Given this list of marker genes PUS7L, DDX18, MIR6090, ITGA4, LINC01068, MRPL40, RNU6-1043P, MEAK7, EVI5, CCDC194, SSBP1, ATXN2L, WIPI2, RNA5S6, S100A2, ZKSCAN3, CWC25, WDR70, KLHL20, TSHZ2, VPS33B-DT, TGFBR3, TMEM242-DT, FAM86B3P, TIMM21, CCDC117, NAA80, MBD1, ZNF821, ARL5AP1, HSPE1-MOB4, ITPRIP, HNRNPR, CCDC90B, COPS7A, BOLA1, FXYD3, KCTD15, TMEM242, RAD50, EPCIP-AS1, RN7SKP276, SIN3B, ORMDL1, RN7SL19P, SPESP1 (NCBI Gene Id 83599), ENSG00000260288 (novel transcript), ZNF214 (zinc finger protein 214), COL4A6, RNU4-71P, MT-TN, SFSWAP, DXO, BMS1P4, CIP2A, PTPN4, TMEM199, ACOT13, EVI2B, SLC33A1, DTL, ZNF518A, TBKBP1, MT-TY, SERTAD3, APOBEC3C, TMEM259, MRTFA-AS1, MNAT1, NLRP14, DYNLL2, ATAD3A, DUSP6, ERVK3-1 (endogenous retrovirus group K3 member 1), BOLA3, ZFP1, WIZ, EIF3F, ENTPD6, RN7SL278P, CAMLG (calcium modulating ligand), WEE2-AS1, ZNF497-AS1, ARID1A, MT-TA, ATPAF1, TM7SF3, MAP2K5, ZNF791, LINC00620, ADIPOR2, COPS2, WNT2B, SRCAP, CNIH3, NUDCD1, RTEL1, MTMR4, PEX14, RABEP2, IRAK4, KAT6A (NCBI Gene Id 7994), FOCAD, FBXO15, DENND2B, PTK2, ABCD3, FBXL4, ARK2N, RAB11A, CIMAP3, ARF3, LINC01535, RSRP1, FAM20C, CCDC88A, ZNF790-AS1, NRSN2, DHX38, NOL12, SPRED1, LINC00963, PACSIN1, ODAD4, BTK, LGALS13, MITF, YJU2B, DUS1L, TRMT5, CLCN6, EBLN3P, MCMBP, MRPS18A, GLUD1P3, LRRC49, ANKRD54, LINC01411 (NCBI Gene Id 101928176), NRSN2-AS1, TIMM17B, ADSL, EIF2B3, NDUFAF4P1, ZNF131, RPS14, PQBP1, TOM1, MAN2C1 (mannosidase alpha class 2C member 1), PLEKHA6, ESYT1, KRI1, APC2, LINC00649, CCDC180, ATP2C2-AS1, NDUFAF5, CDC42SE1, EIF2D, RPL31P61, KCTD5, MMP16, COMMD4, ZFP91, CKAP2, MAP1LC3B, RTL8B, HEMGN, DCAF15, RGL2, KBTBD4, MAGOH-DT, GALK2, SNHG20, PDCL2P2, BZW1, USP3 (ubiquitin specific peptidase 3), ETFA, SAAL1, RMRP, EIF3D, MAD2L1BP, CFAP74, PPP2R2A, BMS1P4-AGAP5, CRBN, MED23, PAAF1, ENPP3, FAM227B, TOR1AIP1, MIR548AA2, RTEL1-TNFRSF6B, CDC45, SLC35A1, EML2, NSUN3, SKA3, RPL34, SIRT7, VPS33B, NF1, IGFLR1, MRPL44, TMEM167B, C1orf35, RCC2P4, EDC4, LONP2, MIR4457, ENSG00000231252, GPRC5C, GPA33, ELAC1, ZNF721, GABPB2, TAF9, DLEU2, RUFY1, SUGT1-DT, HSPE1, DPH1, MYBBP1A, CCR7, ENTPD1-AS1, GINS3, ARID4B, MIS12, ENSG00000237813, ALG10, GPI, RNU5B-4P, MCM3AP, ADAR, NDUFV2, RN7SL521P, CDC42EP3, BCS1L, ZNF491, MTA3, ZNF546, GNAL, ZNF575, ESF1, FRMD4B, METTL5, CREBL2, REEP4, NUP58, DZIP3, MSRB2, FAM136A, NUDT19-DT, TUBGCP3 (NCBI Gene Id 10426), CYP1B1-AS1, DHPS, OR2A1-AS1, KIF20B, ST13P16, TBK1, CDADC1, PUS10, MKNK1, CCDC90B-AS1, LPCAT2, PREX2, RNU6-1176P, TAOK3, ZNF391, APOO, STAT6, EFCAB7, FAH, LAMTOR5, SMG8, ZBTB7B, RPL34-DT, HSPBP1, NR2F2-AS1, THAP12, KIAA0513, YBX3, GPR161, CSTF2T, HIRA, IL10RA, RC3H2, SERPINB6, STARD3NL (STARD3 N-terminal like), STX16-NPEPL1, APOBEC3D, ABCB8 (NCBI Gene Id 11194), ARPC1A, LRP3, NME1-NME2, AK6, USP30, EP400P1, MRPS33, NOC3L, SREK1IP1, POLR3B, CNN3, MIR7-3HG, PAFAH2, HNRNPA1P37, LINC02341, MDC1, LINC02953, ARHGEF7, RNU6-470P, PSAP, ZNF585B (NCBI Gene Id 92285), DDX55, HELQ, HYAL3, RABGAP1L, ACBD5, DNASE1L1, ZNF234, SEH1L, ETS1, RNF224, AAGAB, SNORD60, CARMN, TOMM20, SMIM14, NEAT1, VSTM4, SH2D5, CAND1, RFTN1, HSPD1P21 (heat shock protein family D (Hsp60) member 1 pseudogene 21), DERL2, TCERG1, C18orf21P1, ZNF568, DNAJC25, DHRS13, CNIH3-AS1, CLK3, FAS, USP21, VARS1, BRWD3, KRTAP5-14P, IQCH, ZNF540, PRCC, RN7SL100P, SLC2A1, ZNF300, ACSL1, MTIF2, RNVU1-15, S100PBP, BMPR1A, RPL36A, C19orf12, GALE, CBX1, ZNF112, TAFA2, C2CD6, RAI14, ITGB3BP, FGF13, ZNF330, CALCRL, MARK4, MAP3K12, TTI2, CCNB3, MRTFA, AMOT, CCNO-DT, WWP2, DYRK4, ZNHIT3 (NCBI Gene Id 9326), RNA5SP473, RNU6-1107P, ADAT2, KRBA1, NSMCE1, NCAM1, DNAJC25-GNG10, GFUS, ZYG11A, PTPN2, LINC00868, NACA, RPL12, NSMCE1-DT, METTL3, ASPSCR1, G6PC3, FRA10AC1, KLHDC1, POLR3G, APBA3, CHST11, GAPDHP31, TBC1D19, SCD, ADNP, SDHDP2, SKIC3, TVP23B, COL4A2, TRAM2, ZSCAN16-AS1, NPAT, UQCC6, CTNS (cystinosin, lysosomal cystine transporter), PWWP2A, EYA4, ANO8, CITED2, ARSK (NCBI Gene Id 153642), RIGI, ZNF585A, KLHDC10, TCF4, NUF2, ZNF425, ZNF146, CDK5RAP1, SERTAD3-AS1, ISLR2, ELOCP32 (NCBI Gene Id 106481964), DYNC2I2, CARD8-AS1, DAXX, EEF1D, MEGF10, COX7A2, ZNF490, HMGB1, LAS1L, SEC14L1, BSDC1, SS18, RPL21, BOLA3-DT, CORO1A, SNHG19, LRP1B, PHYH, HTR5A, SYP, PPM1K, DPM3, TLCD5, ENSG00000252923, ZNF582, CCDC85B, COMMD10, PSMD9, MTFR1P1, RPL37, MBLAC2, PAK4, GTF3C5 (NCBI Gene Id 95853), SLC35E2B, ZNF609, UGDH, PRPF3, KNTC1, FMR1, CACNG5, ZSCAN9, SERTAD2, SNX1, B4GALT7, PIEZO1, MATCAP2, UBB, ITCH, TMEM18, USPL1 (ubiquitin specific peptidase like 1), MAGOH, TMEM147, RPA2, LINC02941, RRAS, ARHGAP29-AS1, ACTN4, DEUP1, MAZ, CDHR3 (cadherin related family member 3), PGM1, CDKN2C, IL5, CSRP1, GALT, DRAIC, PRSS27, COX4I1, RPL21P28 (NCBI Gene Id 100131205), LINC02890, MIR1302-3, ATM, SNHG7, ZC3H10, MIR4727 (NCBI Gene Id 100616416), AGAP5, TMEM68, LINC01719, ANK3, NFIA, ARID5B, PRPF18, IDS, SCAMP1, CCDC159, STING1 (NCBI Gene Id 340061, stimulator of interferon response cGAMP interactor 1), TPD52L1, NXPH3, ENSG00000267058 (novel transcript), ZNF223, SPOCD1, GRPEL1, ECHDC1, ZNF410 (zinc finger protein 410), BMP5, EGLN2, COX11P1, SCAND1, ZNF644, WDR36, PEX13, C1orf162, GOLGA1, KLHL11, CTNND1, ERLIN2, ENSG00000233230, VPS51, C12orf76, NAE1, THTPA, SUPT5H, BRD3OS, RNU6-2, ATG5, RGN, KRAS, CCDC103, LINC01547, CYP4X1, TMC7, CACNB3, PLD1, NUDT19, RHOC, DUSP22, ROR2, CLUL1, KRT18P68, STX16, NME9, USP15, CLIP1, HDGF, MCM3, KDSR, ACTR3B, KPNB1, POLDIP2, PPP6C, ZBED6, H3-3B, EIF5, RPS4XP20, RINT1, NARS2, C11orf68, GLS2, MRPL30, TUBG2, TPST2, USP31, SMARCD2, SEC23IP, GNB2, GCLC (glutamate-cysteine ligase catalytic subunit), CNBD2, HGS, DYNLL2-DT, NMRAL1, CCBE1, RPL38, GSTCD, MORF4L1, SNAP91, GOT2, DMAP1 (DNA methyltransferase 1 associated protein 1), ATE1OSP, ZNF280D, LINC01981, RPS3A, HIVEP3, SMIM26, RBPMS, RARS2, RMND1 (required for meiotic nuclear division 1 homolog), SDAD1, RFXAP, LINC02846, PRMT5, NRBF2, DHFR2, SNAP47, TFEB, TEX38, ZNF212 (NCBI Gene Id 7988), LINC02293, HMGA2, NPAS3, ZSCAN25, CFAP276, AARSD1, GTF2H4 (NCBI Gene Id 2968, general transcription factor IIH subunit 4), RNA5SP516, TAF15, INTS4, RESF1, COL4A1, METAP2, ACTA2, MYOM2, TAMM41, PLCE1, AASDHPPT, HCG9, DYNLL1, JPX, ZNF524, LSM8, RPP40, RNU6-535P (NCBI Gene Id 106479803), RNU7-179P, UFD1, CCNO, BEND2, ZNF566, CLIC4, MT-TC, TMBIM6, CAV2, SLC35A3, ZKSCAN4, ZNF829 (NCBI Gene Id 374899), FAF1, SMARCA1, DTD1, MIR7-3, E2F7, ST3GAL1, CNNM2, TXNL4B, METTL16, RHOBTB3, GPR37, IQCK, IREB2, RPL36A-HNRNPH2, OLIG1, URGCP, NKAP, GGACT, TDP2 (tyrosyl-DNA phosphodiesterase 2), BRK1, ABR, MIR5188, HIKESHI, RSRC2, ANKRD46, CSDE1, MRPL58, TMEM9, SMG5, CWC27 (CWC27 spliceosome associated cyclophilin), HEBP2, RAI1, POLDIP3, TBX18, GAPVD1, DAB1, RNU5A-8P, WTAP, AURKAIP1, RBMX2, ABCD4, RGS5, CEP170, KIF2A, RPL19, MRPS14, SLC24A1, PPP4R1, INTS12, H1-2, INTS14, RNU5A-5P, GFM2, NR1H3, CKAP4, CXXC1, ACP2, C17orf75, ACOXL, SMPD4P1, PSMA6, CHD3, SH3BGRL2, UTS2B (NCBI Gene Id 257313), THAP10, IGHMBP2, SYT4, ZNF264, ZNF461, DIO3OS, GEMIN7, ZNF396, ZNF565, RNU6-947P, COL4A5, TASOR2, RNF6, PMS1, ZNF404, STAT1, RNU11, DISC1, EPS15, ATP6V0A2 (NCBI Gene Id 7854), ATRX, ENSG00000212187, UROS, ELOVL1, TRIP10 (thyroid hormone receptor interactor 10), LARS2, NRAV (negative regulator of antiviral response), RN7SL322P, RPL27, PLEKHM3, CCDC107, BCL2L2, FAM187A, VARS2, CAV1, VRTN, PPM1K-DT, TCF12, MT-TF, NUDT17, PCBP1-AS1, TYW1, MLEC, NSUN4, OPTN, STK19, TUBD1, ATP6AP1L, MEMO1, MRPS18C, MT-RNR1, PAX9, PML, TMEM54, MITD1, CBX5, CNIH3-AS2, TSFM, CDCA4P2, ENC1, BCL2L2-PABPN1, TRPV2, MSL2, SCN8A, SUGT1, TATDN2, UEVLD, DTWD1, VDAC3, OCEL1, GTPBP3, TMTC2, VDAC2P2, WDR11-DT, ERVFRD-1, SMIM8, SERTAD1, C2CD5, CEP164, IL2RB, ZNF582-DT, DCP1A, BLOC1S1, HSPD1, EXOSC3, LAMTOR5-AS1, EP300, MED18, ENSG00000267448, HACD3, PAQR4, KCNK1, UBC, STMN3, MAPK14, SMG7, CTSC, MIR4530, ZFP30, POLR2KP2, EMC8, SLC38A6, NDUFS7, BRD7, ZKSCAN8P1, ZNF571 (NCBI Gene Id 55594), KPNB1-DT, ADRA1A, BLOC1S6 (biogenesis of lysosomal organelles complex 1 subunit 6), MYO19, ITPR1, NAPG, SNRNP27, TPR, FMC1, FIZ1, MIGA2, FMC1-LUC7L2, LINC01703, MRPL54, LINC01775, ENSG00000232995, TPGS1 (NCBI Gene Id 91978), MTHFR, FUT10, GBA1, RPL7L1, RYK, HIGD1AP5, GON4L, COA4, ZNF175, AKR1A1, MRPS31P4, CCDC9, ASF1A, STRADA, LINC02896, PSPC1, FKBP7, DCLRE1A, CCDC14, CEP72, TIMM44, ALDH7A1, MUC20-OT1, ICAM4, ARMT1, ZNF221, ELAPOR1, ZNF106 (NCBI Gene Id 64397), CEP126, ABCF2, UBE3D, ZBTB11, LRRC71, SMG7-AS1, YBEY, CMAHP, RN7SL819P, RXYLT1, SSR3, GPR108, VPS25, YARS1, TMEM170A, SCAPER, MIR4676, IGFBP6, CFAP298, SLX9, RGS14, TMEM19, LDAF1, PARK7, UTP3, NR3C1, OGT, ZNF251, ZNF302, MDP1, MIR4662B, KDM1A, YWHAQ, ZNF550, CBX1P2, SSBP2, TRABD (TraB domain containing), MTR, ZNF398, N4BP3 (NCBI Gene Id 23138), CNTLN, SLCO5A1, DNAJB4, NME1, DRAP1, ZSCAN22, EXOSC8P1, SNAP23, CIZ1, TRAF7, VPS26A, POMT2, RNU6-142P, ADGRL2, ENSG00000247416, ARMC5, COL21A1, PPP1R15A, LRRC14B, LRSAM1, ZNF607, BCCIP, AP4B1, SPOP, POLD2 (NCBI Gene Id 5425), MIR4662A, CA5BP1, GGPS1 (NCBI Gene Id 9453), AARS2, NHLRC2, MTF2, LINC02136, EIF1, MISFA, SCN1A, NEMP2, MTCO3P12, ZNF227, MVB12A, CCDC178, RPL32P28, CFAP298-TCP10L, ZNF385A, GATAD1, TMEM79, TRAM2-AS1, BAZ2A, STRA6, BAZ2B (NCBI Gene Id 29994), PPT1, DPP9, HLA-F, CDK13, PAIP2, APEX2, NSA2, MIR4734 (microRNA 4734), EPS8, TMEM101, DPY19L4 (dpy-19 like 4), RNA5SP117, IPO4, CDK12, FILIP1, KAZALD1, SZRD1, SNRPE, PRMT5-DT, RAD17, PIGG, NOPCHAP1, RAF1, TLE6, MRPL21, RN7SL262P, PEX3, CRYM, TBCB, ZNF81, DIAPH1, ATG16L2, EXOC1, PEX11G, TTN-AS1, FAM151B-DT, ZNF25-DT, ZNF25, SIGMAR1, MBTPS1-DT, IGF2BP2, ANXA2R, NFIC (nuclear factor I C), TACO1, CDC42EP4, IQSEC2, EFTUD2, TJP1, TGS1, ATG101, SRSF3, POLR2I, FAM151B, TCF4-AS2, ENSG00000233017, PLCB2-AS1, DDX41, GLYR1, MRPL57, TGFB1, JMJD4, ENPP4, NR2F1, ALDH3A2, AP3S2, MARS1, NPFFR1, PPP6R1, RPL12P20, UBE2N, JMJD1C, MIR5194, RPL3P2, DCDC2B, TMEM147-AS1, SF3A3, ANKRD13C, FBXO31, ANKEF1, MIR194-1, MRPS35, SMIM14-DT, WDR11 (WD repeat domain 11), ITGA7, PAXBP1, KBTBD3, ANP32A, NDUFS3, PPP1R8, LPXN, RPL7P24, TMEM219, NRP1, DCLRE1B, ENSG00000273162, ZSCAN20, GNPDA1, LINC00486, RPS6KB1, TTLL1, here is a description of the gene set: species: Homo sapiens Genes containing one or more binding sites for (ZNF8) in their promoter regions (TSS -1000,+100 bp) as identified by GTRD version 20.06 ChIP-seq harmonization. from publication Yevshin I, Sharipov R, Kolmykov S, Kondrakhin Y, Kolpakov F (PMID 30445619) Human Gene Set: ZNF8_TARGET_GENES